Given this list of marker genes UBL5, YJU2, SNIP1, SRSF5, EFTUD2, SAP18, FAM32A, HTATSF1, U2AF2, GTF2F1, SMU1, DHX8, CWF19L2, PTBP1, PCBP2, CWC15, WBP4, SF3B1 (splicing factor 3b subunit 1), SNW1, AQR, SNRPB2, NSRP1, DDX41, USP39, PHF5A, CWC25, TRA2B, LSM7, SF3A2, FUS, HNRNPC (heterogeneous nuclear ribonucleoprotein C), U2AF1, SLU7, ZMAT2, DHX16, GPKOW, U2SURP, PRPF6 (pre-mRNA processing factor 6), CASC3, DDX42, RNF113A, SRSF10, STEEP1, POLR2B, HSPA8, SNRPD2, DDX46, RBM5, DDX39B, PRPF38A, SF1, PPIG, SRSF7, DDX23, POLR2I, HNRNPR (NCBI Gene Id 10236), BUD31, HNRNPU, RBM25, SUGP1, MAGOH, SYF2, SNRNP200, FAM50A, CACTIN, MAGOHB, HNRNPM, SNRPN, POLR2K, LSM8, TFIP11, SMNDC1 (survival motor neuron domain containing 1), SRSF12, SNRPB, SF3A1, GPATCH1, CWC27, SF3B5, WBP11, SNRNP27, SRSF11, EIF4A3, SNRPC, SNRPF, PPIH, DDX5, IK, HNRNPL, LSM6, RBM10, HNRNPH1, PNN, SF3B6, DHX9, PPIE, PPWD1, SRSF1, SF3B4 (splicing factor 3b subunit 4), CCDC12, ALYREF, SNRPE, CDC5L, BCAS2, PPIL2, BUD13, SRRM1, PPP1R8, PRKRIP1, PRPF4, POLR2F, PPIL1, DHX15, MTREX, POLR2G, LSM2, HNRNPK, CRNKL1 (crooked neck pre-mRNA splicing factor 1), SRSF6, PLRG1, POLR2D, HNRNPA1, SRRM2, RBM39, SRSF9, RBMX2, LSM3, PRPF18, DNAJC8, RBM22, RBM8A, LSM4, GCFC2, PRPF3, TCERG1, RBM42, DHX35 (DEAH-box helicase 35), SNRNP40, SNRPG, XAB2, SNRPA1, POLR2C, PRP4K, CTNNBL1, MFAP1, SNRPA, SRSF3, ISY1, PRPF8, UPF3B, YBX1, SART1, SF3B3, NCBP1, DHX38, POLR2E, U2AF1L4, PRPF40A, HNRNPF, C9orf78, POLR2L, HNRNPD, SDE2, LSM5, SF3A3, PUF60, WDR70, PRPF31, PCBP1, RBMX, SRSF4, ZNF830, SNRPD1, CCAR1, POLR2J, CWC22, PRPF19, RBM7, SRSF8, RNPS1, PRCC (NCBI Gene Id 5546), HNRNPA2B1, PQBP1, SF3B2, TXNL4A, GTF2F2, HNRNPA3, SRRT, NKAP, SRSF2, SNRPD3, PPIL3, RBM17, ACIN1, LUC7L3, POLR2A, HNRNPH2, SNU13, LENG1, NCBP2, PPIL4, SNRNP70, CDC40 (cell division cycle 40), POLR2H (RNA polymerase II, I and III subunit H), CHERP, here is a description of the gene set: part of: mRNA Splicing studied in species Homo sapiens Reactome Pathway: mRNA Splicing - Major Pathway Eukaryotic genes are transcribed to yield pre-mRNAs that are processed to add methyl guanosine cap structures and polyadenylate tails and to splice together segments of a pre-mRNA termed exons, thereby removing segments termed introns. More than 90% of human genes contain introns, with an average of 4.0 introns per gene and 3413 nucleotides per intron compared with 5.0 exons per gene and 50.9 nucleotides per exon. (Notable exceptions are the histone genes, which are intronless.) <br>Pre-mRNA splicing is performed by a large ribonucleoprotein complex, the spliceosome, which contains 5 small nuclear RNAs (snRNAs) and more than 150 proteins. The catalyst in the spliceosome comprises magnesium ions coordinated by the U6 snRNA that catalyze transesterification reactions between hydroxyl groups and phosphate groups from the pre-mRNA. The role of the U6 snRNA demonstrates that the spliceosome is a ribozyme hints at the origin of the spliceosome as a self-splicing group II intron. <br>The spliceosome is initially assembled cotranscriptionally on the pre-mRNA as the Spliceosomal E (Early) complex and then remodelled sequentially by association and dissociation of proteins and snRNAs to catalyze of the two reactions of splicing. First, a nucleophilic attack by the 2' hydroxyl group of a conserved adenine residue, the branch point, within the intron on the phosphate group of the 5' residue of the intron yields a lariat (looped) structure in the intron joined to the downstream (3') exon and a free upstream exon with a 3' hydroxyl group. Second, a nucleophilic attack by the 3' hydroxyl group of the upstream exon on the phosphate of the 5' residue of the downstream exon yields a spliced mRNA containing the upstream exon ligated to the downstream exon and a free intron containing a lariat structure. <br>The Spliceosomal E complex contains the U1 snRNP bound to the 5' splice site, SF1 bound to the branch point, and the U2AF complex bound to the polypyrimidine tract of the intron and the 3' splice site of the pre-mRNA. SF1 and U2AF are displaced on the pre-mRNA and the U2 snRNP binds the branch region to yield the Spliceosomal A complex. The U4/U6.U5 tri-snRNP, containing the U4 snRNA base-paired with the U6 snRNA plus the U5 snRNP and accessory proteins, binds the Spliceosomal A complex to form the Spliceosomal Pre-B complex. The U1 snRNP is replaced at the 5' splice site by the U6 snRNA and the spliceosome is remodelled to yield the Spliceosomal B complex. The Spliceosomal B complex is activated to form the Spliceosomal Bact complex by dissociation of the U4 snRNP and Lsm proteins from the U6 snRNA, freeing the U6 snRNA to form the active site of the spliceosome. Dissociation of the SF3A and SF3B subcomplexes of the U2 snRNP allows the intron branch point to dock near the 5' splice site, forming the B* Spliceosomal complex. Reaction of the branch point at the 5' splice site, yields the Spliceosomal C complex. The branch point is rotated to allow the 3' splice site to enter the active site, yielding the Spliceosomal C* complex. Reaction of the 3' hydroxyl group of the upstream exon at the 3' splice site yields the Spliceosomal P (postcatalytic) complex. The Spliceosomal P complex then dissociates to yield an mRNP containing the spliced mRNA and associated proteins, including the exon junction complex (EJC), and the Intron Lariat Spliceosome (ILS), which contains the intron lariat. The ILS is then disassembled to free its components for further splicing reactions and the intron lariat is degraded.